The following is a description of a gene set: An abnormally high level of uric acid in the urine. Human Gene Set: HP_HYPERURICOSURIA studied in species Homo sapiens Hyperuricosuria, and this is the list of marker genes: HPRT1, PRPS1, EHHADH, SLC34A1, SLC2A9, SLC22A12, CLDN16, ALDOB, GATM, NDUFAF6